The following is a description of a gene set: Enables the transfer of pyruvate, 2-oxopropanoate, from one side of a membrane to the other. Human Gene Set: GOMF_PYRUVATE_TRANSMEMBRANE_TRANSPORTER_ACTIVITY species: Homo sapiens, and this is the list of marker genes: MPC1L, SLC16A11, MPC1, SLC16A3, MPC2, SLC16A7